The following is a description of a gene set: Mouse Gene Set: GOBP_CEREBRAL_CORTEX_GABAERGIC_INTERNEURON_MIGRATION studied in species Mus musculus The migration of GABAergic interneuron precursors from the subpallium to the cerebral cortex., and this is the list of marker genes: Arx, Fezf2, Lhx6, Cntn2, Drd1, Drd2